Given this list of marker genes MYH7, GLIS2, IGSF6, DBP, NR1D2, IFT70B, DUSP2, RBM38, ADD1, ANP32E, CD79A, ZDHHC14, TMPRSS2, CHST12, FKBP3, FAIM, DDR1, PRXL2B, PTPRO, SLC52A3, EPB41L5, AP3M2, ANO1, MMP11, CD247, HOXA5, PNLIPRP1, EPHX1, FIG4, CDKN2C, PTPA, MEOX2, ADISSP, PLXDC1, SMIM8, TSPAN15 (tetraspanin 15), HYI, CLN6, PTPRE, OXTR, ARHGAP9, ST8SIA2, LAT, RRM2B, SPATA13, PPIF, OAS1, ANTKMT, CAPN1, DKK3, FOXP1, SERPINB1, GMPR, ADH1C, ART4, PYCARD, H1-0, KLRD1, SIDT1, RAD51AP1, GAMT, PDCD4, ISLR, FABP3, NREP, RTP4, EPHA1, SFXN3, IL7R, TEX261, EXTL2, DAPK2 (death associated protein kinase 2), CNN2, PARP12, FAM174B, EVA1A, PSMB8, NUP37, SMPDL3B, GREM2, LRRC23, G0S2, FUS (NCBI Gene Id 406232), LIMD2, CAVIN2, PTPRS, RASD2, B3GNT9, TTI2, KHDRBS1, PER3, ATP1A2, TMEM119, SATB1, AQP5, ICOSLG, BEX2, FBLN5, EXOSC8, ENOX2, TENT5C, PDGFA, IL15 (interleukin 15), VIPAS39, HLF, CYB561D2, NRP2, LPP-AS2, RFX5, HFE, MAPK12, BLNK, EBPL (EBP like), PLIN3, C19orf48P, ACVR2B, CIRBP, LAMA3, EFNA1, WDR6, JARID2, SORT1, TK2, SRI, SLC1A5, SRPX2, GASK1B, PCBP4, HDDC2, CD3D, TMTC4, GLCCI1, BRI3, SPATS2L, SASH3, LCMT1, IFIH1, RERE (NCBI Gene Id 9642), SLC12A7, CD79B, ABCG1, HDAC7, MORN4, DDX42, DERL1, TPST1, PTP4A3, BCL11B, ADCY8, CCN5, PLCE1, CUEDC1 (CUE domain containing 1), PRDM1, CNR2, PLVAP (plasmalemma vesicle associated protein), SEPTIN4 (NCBI Gene Id 5414), GUK1, CCR2, SLC25A47, TAP1, SLC4A3, EPB41L3, NR1D1, MLH3, CSF1R, MYO6, LSP1, ECRG4, PLEKHA6, NOTUM, RGS10, CD3G, MCUB, FABP1, PLXND1, RALGPS2, DTX1, HLA-DOA, RGS2, DDX59, LYSMD2, SOX4, TMEM143, METRN (NCBI Gene Id 79006), CMTM7, ALPL, IQGAP1, OSBPL5, ELP2, AFG1L, RDH14, CD19, PLAC8, MRPS35, EBF1, ANGPTL2, RBP1, PRKCB, KLK8, here is a description of the gene set: Human Gene Set: GSE20715_0H_VS_24H_OZONE_TLR4_KO_LUNG_UP from publication Bauer AK, Rondini EA, Hummel KA, Degraff LM, Walker C, Jedlicka AE, Kleeberger SR (PMID 21543283) Genes up-regulated in comparison of lung tissue from wild type mice subjected to ozone for 0 h versus that from TLR4 deficient mice subjected to ozone for 24 h. species: Homo sapiens We previously identified toll-like receptor 4 (Tlr4) as a candidate gene responsible for ozone (O3)-induced pulmonary hyperpermeability and inflammation. The objective of this study was to determine the mechanism through which TLR4 modulates O3-induced pulmonary responses and to utilize transcriptomics to determine TLR4 effector molecules. C3H/HeJ (HeJ; Tlr4 mutant) and C3H/HeOuJ (OuJ; Tlr4 normal), mice were exposed continuously to 0.3 ppm O3 or filtered air for 6, 24, 48 or 72 hr. Affymetrix Mouse430A_MOE gene arrays were used to analyze lung homogenates from HeJ and OuJ mice followed using a bioinformatic analysis. Inflammation was assessed by bronchoalveolar lavage and molecular analysis by ELISA, immunoblotting, and transcription factor activity. TLR4 signals through both the MYD88-dependent and independent pathways in OuJ mice, which involves MAP kinase activation, NF-kappaB, AP-1, and KC. Microarray analyses identifiedTLR4 responsive genes for strain and time in OuJ versus HeJ mice (p<0.05). One significantly upregulated cluster of genes in OuJ were the heat shock proteins (Hspa1b; Hsp70), Hsp90ab1). Furthermore, O3-induced expression of HSP70 protein was increased in OuJ compared to HeJ mice following 24-48 h O3. Moreover, BAL polymorphonuclear leukocytes (PMN) and total protein were significantly reduced in response to O3 in Hspa1a/Hspa1btm1Dix (Hsp70-/-) compared to Hsp70+/+ mice (p<0.05). TLR4 signaling (MYD88-dependent), ERK1/2, AP-1 activity, and KC protein content were also significantly reduced after O3 exposure in Hsp70-/- compared to Hsp70+/+ mice (p<0.05). These studies suggest that HSP70 is involved in the regulation of O3-induced lung inflammation through the TLR4 pathway and provide evidence that HSP70 is an endogenous in vivo TLR4 ligand.